The following is a description of a gene set: Human Gene Set: GOMF_R_SMAD_BINDING species: Homo sapiens Binding to a receptor-regulated SMAD signaling protein., and this is the list of marker genes: ZEB2, PPARG, SMAD2, DROSHA, FOS, FOXH1, MYOCD, AXIN1, LDLRAD4, MEN1, PPM1A, RANBP3, PARP1 (poly(ADP-ribose) polymerase 1), TRIM33, SMURF1, MTMR4, ZC3H3, ANKRD1, PAX6, SMAD3, PMEPA1, DDX5, RGCC, SMAD4, JUN, SMAD6, STUB1